Given this list of marker genes FAP (NCBI Gene Id 2191), CDK11A, MSTN, SMAD1, TTLL6, PITX2, POU3F3, FAM53B, SAMD3, XK, RHOQ, GCNT2, PDZD2, PPP1CB, HOXA9, MBNL2, DLX1, LIX1, HOXA11, MYO18A, GRHL3, MYH2, PARD6A, OFCC1 (NCBI Gene Id 285807), CALCRL, TAPBP, DMTF1, LCOR, LMO4, LHX1, GET4, BNC2, CFAP161, TFAP4, TGFB3, MEIS1, ZFP36L1, ZBTB10, DSEL, GPC3, MAP4K4, HOXB7, MYCBP, DYNC1LI2, PRKACB, TMEM88, ECHDC2, NCOR1, UBE2E4P, CERT1, DDX17, CTCF, KRT14, SNCAIP, AP1S2, MTCH2, STC1, UBXN10, MPRIP, IKZF2, LHX6, VAMP3, TBX2, NPAS3 (neuronal PAS domain protein 3), HHEX, LMNA, TNNC1, CRYGD, PHF3, HOXB3, BHLHE41, TMEM164, DPYSL2, POU2F1, MAPK10, XPO1, GPATCH2, PLS3, BCL6, HOXD3, FMO3, ATP2B3, PPP2R1B, EIF4G2, POLK, PCDHA7, DIO2, MRPL28, CEP15, NIPBL, HAPLN2, DYNC1LI1, HDAC9, NOSIP, PUM2, ESRRG, CS, BCL11A, HBP1, NOG, NRXN3, AP1G1, SCML4 (Scm polycomb group protein like 4), NCALD, RNF144B, ZNF827, JADE3, ENSG00000291228, FLRT1 (fibronectin leucine rich transmembrane protein 1), ID3 (NCBI Gene Id 3399), NFIX, SLC5A12, IGF1 (insulin like growth factor 1), C17orf50, MMP27, POU4F2, TMEM131L, FOXD3, CNTFR (NCBI Gene Id 1271), TMEM62, BMP5, ROGDI, DRD3, ACRV1, NR5A2, SPARC, ANKRD28, TNIP3, ADGRF1, RAB3IP, PRICKLE1, WBP2NL, USP13, INO80, TYRO3, EML4, YPEL4, RDH10 (retinol dehydrogenase 10), TLE4 (TLE family member 4, transcriptional corepressor), SOX2, AFP, CSF3 (colony stimulating factor 3), CDKL5, NCKAP5, PROK2, PRKAG1, DUSP10, SCML1, ANPEP, TUBA1A, TSHB, DMD, DLG2, CASP8, LUC7L3, LRFN5, SOX4, SFXN5, HIVEP3, TDRD5, LUC7L, PCYT2, FBXL19, PIK3R1, STAG2, LEMD1, JAG1, FOXA2, CTNNBIP1, MACROH2A1, MTPAP, VLDLR (very low density lipoprotein receptor), RGS3, SRSF2, SYNCRIP, RCC2, ADAM11 (NCBI Gene Id 4185), H3-3B, HSD17B2, KIF1B, P2RY10, ANP32D, PLPP7, RTL9, MBNL1, HOXA4, RIN2, ATP6V1E2, POU4F1, AXL, PTGR3, RCOR1 (REST corepressor 1), CADM2, PNMA1, ASIC4, TGIF1, PNPLA6, ST8SIA2, GPR156, FBN2, CDK11B, SCHIP1, LCT, ARFGEF1, MAP2K6, TMEM95, COLCA1, BARHL1, RBFOX1, ADAM28, CYFIP2, PJA1, FBXL19-AS1, LRRN3, HOXC11, RBP4, CA4 (carbonic anhydrase 4), CHD2, STEAP2, GPR27, PREX2, SEZ6, TFDP2, CITED2, TET2, CHRDL1 (NCBI Gene Id 91851), ELF4, CACNA2D3, MECOM, SSMEM1, IP6K2, TNKS1BP1, ZIC1, SPATA17, FOXP2, here is a description of the gene set: Human Gene Set: HP1SITEFACTOR_Q6 Genes having at least one occurrence of the motif AATWTTCAACAG in the regions spanning 4 kb centered on their transcription starting sites. This matches the transcription factor binding site V$HP1SITEFACTOR_Q6 (v7.4 TRANSFAC). studied in species Homo sapiens